The following is a description of a gene set: Genes bound and activated by ZNF217 in MCF7 cells (breast cancer). species: Homo sapiens Human Gene Set: THILLAINADESAN_ZNF217_TARGETS_UP from publication Thillainadesan G, Isovic M, Loney E, Andrews J, Tini M, Torchia J (PMID 18625718) The ZNF217 oncoprotein is a constituent of a core transcriptional complex that includes CoREST, histone deacetylase 1/2, lysine demethylase 1, and the C-terminal binding protein 1/2. We have combined genome-wide expression profiling and chromatin immunoprecipitation with directed selection and ligation (ChIP-DSL) to identify a subset of genes directly regulated by ZNF217. Our results establish p15(ink4b) as a direct target of the ZNF217 complex. Downregulation of ZNF217 in MCF-7 breast cancer cells resulted in a dramatic increase in p15(ink4b) expression and coincided with increases in dimethylation of H3-K4 and, surprisingly, a decrease in K9/K14-H3 acetylation. Stimulation of HaCaT cells with transforming growth factor beta (TGF-beta) resulted in a release of ZNF217 and a concomitant binding of SMAD2 to the proximal promoter, which preceded increases in ink4b protein expression. Furthermore, the changes in chromatin marks at the p15(ink4b) promoter following TGF-beta stimulation were similar to those observed following ZNF217 downregulation. Collectively, these results establish the ZNF217 complex as a novel negative regulator of the p15(ink4b) gene and may constitute an important link between amplification of ZNF217 and the loss of TGF-beta responsiveness in breast cancer., and this is the list of marker genes: IRX2, RAD51AP1, CNOT1, DAZAP1, CDC25C, FGFRL1, NUP50, CDCA8, EIF4E, MND1, SF3A1, FAM43A (NCBI Gene Id 131583), PRR11, XPO4, ZNF395, KCTD15, BRCA1, TCF3, ETF1, PFKFB3, HDHD5, SKA3, HAUS3, HAUS2, DCXR, LMNB1, POP7, CALM1, CENPU, SRP72, BAIAP2L1, MCM8, OTULINL, PDXP, CABIN1, CAMK2N1, GLT8D1, RAC3, SHLD2, CNPY3 (NCBI Gene Id 10695), LBR